Given this list of marker genes RPL39L, RPL8, RPS15A (ribosomal protein S15a), RPL19, RPL37, RPS2, RPL3L, RPL34, MARS1, EEFSEC, RPL23A, RPL24, RPL15, RPS26, RPL6, RPS7, RPL26, RPS4X, RPL39, SCLY, RPL22L1, RPS9, RPS29, RPL27A, MAT1A, RPL18A, RPL9, RPL26L1, RPL35, RPS15, CTH, PAPSS2, RPS11, AIMP2, RPS13, EEF1E1, RPL36A, RPL31, KARS1, RPL7, LARS1, RPS19, RPL28, RPL29, RPL18, RPS4Y1 (NCBI Gene Id 6192), RPL22, RPS4Y2, RPL13A, RPL10A, RPL30, RPS23, RPL11, RPL10L, RPS21, RPS3, CBS, RPL36AL, RPS12, QARS1, RPL10, RPL41, RPL12, RPLP2 (NCBI Gene Id 6181), RPL23, PAPSS1, SARS1, RPL35A, RPL32, RPS17, EPRS1, SECISBP2, RPS27, RPL17, RPLP1, RPL3 (ribosomal protein L3), FAU, TXNRD1 (thioredoxin reductase 1), PSTK, GSR, RPS28, RPS3A, RPS10, GNMT, RPS20, RPS18, SEPHS2, RPL27, HNMT, RPL5, RARS1, RPS24, RPS5, RPL4, RPL36 (NCBI Gene Id 92364), RPLP0 (ribosomal protein lateral stalk subunit P0), IARS1 (NCBI Gene Id 3376), RPL13, RPL7A, RPS14, INMT, AIMP1, RPSA, NNMT, RPS6, RPS27L (ribosomal protein S27 like), UBA52, RPS8, RPS16, RPS25, DARS1, RPL14, RPL21, AHCY, RPL37A, SEPSECS, RPL38, RPS27A, here is a description of the gene set: Selenoamino acid metabolism species: Homo sapiens Human Gene Set: REACTOME_SELENOAMINO_ACID_METABOLISM